Given this list of marker genes Aadat, Dlst, Pipox, Aasdhppt, Aass, here is a description of the gene set: Mouse Gene Set: GOBP_LYSINE_METABOLIC_PROCESS studied in species Mus musculus The chemical reactions and pathways involving lysine, 2,6-diaminohexanoic acid.